The following is a description of a gene set: species: Homo sapiens Human Gene Set: HP_DISTAL_JOINT_HYPERMOBILITY Distal joint hypermobility Lack of stability of a distal joint (e.g., finger)., and this is the list of marker genes: COL6A1, CRELD1, ALG2, PYROXD1, PLOD1, COL13A1, COMP, COL6A3, COL12A1 (collagen type XII alpha 1 chain)